The following is a description of a gene set: Mouse Gene Set: GOBP_REGULATION_OF_CRISTAE_FORMATION species: Mus musculus Any process that modulates the frequency, rate or extent of cristae formation., and this is the list of marker genes: Pink1 (NCBI Gene Id 68943), Adck1, Chchd10, Oma1 (OMA1 zinc metallopeptidase), Micu1